The following is a description of a gene set: Any process in which a ribonucleoprotein complex is transported to, or maintained in, a specific location within a cell. species: Mus musculus Mouse Gene Set: GOBP_RIBONUCLEOPROTEIN_COMPLEX_LOCALIZATION, and this is the list of marker genes: Riok2, Thoc5, Wnk1, Rbm10, Iws1, Supt6, Thoc2, Akap8l, Alkbh5, Setd2, Prpf31, Nsun2